Given this list of marker genes CYP4F8, CYP4F2, CYP4F12, CYP4F11, CBR3, CYP4F3, here is a description of the gene set: species: Homo sapiens The chemical reactions and pathways resulting in the breakdown of any of the forms of vitamin K, quinone-derived vitamins which are involved in the synthesis of blood-clotting factors in mammals. Human Gene Set: GOBP_VITAMIN_K_CATABOLIC_PROCESS